Given this list of marker genes Cd3g, Fas (NCBI Gene Id 14102), Atg5, Cd28, Card11, Srf, Ptpn2, Tox, Ccr7, Cd1d1, Dock2 (NCBI Gene Id 94176), Gata3, Skint1, Stk11, H2-DMa, Itpkb, Cd3e (CD3 antigen, epsilon polypeptide), Cd74, Ptprc, Jag2, Shh, Foxn1, Nfatc3, Spn, Zap70, Cd3d (CD3 antigen, delta polypeptide), Mink1, Aire, Gli3 (NCBI Gene Id 14634), here is a description of the gene set: Mouse Gene Set: GOBP_THYMIC_T_CELL_SELECTION The process of T cell selection that occurs in the thymus. species: Mus musculus